The following is a description of a gene set: studied in species Homo sapiens Human Gene Set: HP_APLASIA_HYPOPLASIA_INVOLVING_THE_SKELETAL_MUSCULATURE Aplasia/Hypoplasia involving the skeletal musculature Absence or underdevelopment of the musculature., and this is the list of marker genes: TRPV4 (NCBI Gene Id 8098), TBX3, SALL4, POMT1, HBB, MAP3K20, CRPPA, ALG9, HACD1, TGFBR1, ITPR1, GLE1, COL4A1, POMT2, RBM8A (NCBI Gene Id 9939), PIEZO2, FLVCR2, ACTA1, REV3L, TPM2, COLEC11, CHRNA1, MAP3K7, LARGE1, TBX5, LMX1B (LIM homeobox transcription factor 1 beta), ATP6V0A2, ITGA7, FKTN, FKRP, RXYLT1, TPM3, POMGNT2, SIL1, POMGNT1, B4GAT1 (NCBI Gene Id 11041), MYL2, CHRND, PLXND1, POMK, SELENON, CAV3, CHRNG, SCN4A, PMP22, FBN2, B3GALNT2, FLNA, DAG1, MYMX, MYMK